The following is a description of a gene set: A type of non-canonical Wnt signaling pathway in which Wnt binding to its receptor on the surface of a target cell results in the activation small G proteins such as Rho, Rac, and Cdc42 which, in turn activate effectors, including C-Jun N-terminal kinase (JNK) and Rho kinase (Rok). The signaling ends with change in the transcription of target genes and/or reorganisation of the cytoskeleton. Mouse Gene Set: GOBP_WNT_SIGNALING_PATHWAY_PLANAR_CELL_POLARITY_PATHWAY species: Mus musculus, and this is the list of marker genes: Mks1, Sfrp1, Prickle1, Dab2, Ryk, Dvl2, Znrf3, Celsr3, Ankrd6, Med12, Cthrc1, Plekha4, Nkd1, Mllt3, Ror2, Wnt5a, Nphp3, Ccdc88c, Abl1, Fzd6, Wnt7a, Gpc3, Dvl1, Wnt7b, Vangl2, Wnt9b, Dact1, Spef1, Fzd3, Rac1, Abl2, Dvl3